The following is a description of a gene set: from publication Chen Y, Wang X (PMID 31504780) Human Gene Set: MIR4311 studied in species Homo sapiens Genes predicted to be targets of miRBase v22 microRNA hsa-miR-4311 in miRDB v6.0 with MirTarget v4 prediction scores > 80 (high confidence targets)., and this is the list of marker genes: AMOT, AFF4, ACVR1C, ARID4B, KIF5B, C2CD2L, DNAJC21, PDLIM5, KAT6A, SNURF, OXR1, AAK1, HSFY2, RASGRF2, CIP2A, SLC24A4, CMAS, LAMP2, CDIP1, TOM1L1, RRP36, UBQLN2, EN2, PLAG1, PTPRR, TATDN3, CATSPERB, HIRIP3, AFP, DIP2C, NDUFB5, AFF2, ZKSCAN1, COLGALT2, TFAP4, NAB2, LCTL, CETN2, SSBP3, KIAA1549, GNRHR, GTF2A1, BAZ2B, MLF1, UBXN4, PAG1, SOX5, LSM12, CLCC1, LANCL1, PALS2, DAW1, MSI2, ERLIN1, LPGAT1, THSD4, STK40, NEXN, SLC4A8, MYLK4, SETD7, TRMT13, SSBP2, PHKG1, RBMS3, RORA, SNX27, NFAT5, IRAK1BP1, ZBTB20, PFDN2, DDX5, VCAN, AURKC, RFX7, WRN, SARAF, SIX4, ABHD17B, TMEM178A, BTBD7, PDE10A, CMTM4, HDAC9, MTTP, GABPA, MTERF4, GRM7, SSX2IP, OTUD4, CPNE8, ATF7, FRA10AC1, RDH10, TENM1, HSD3B2, DCX, MRPL19, SRFBP1, CALCR, LINC02693, MBTD1, C11orf87, CALM1, NEGR1, PRKD3, AR, CPNE3, ALPL, P2RY10, SOX9, VNN1, ZDHHC9, ZNF521, A1CF, SLC17A8, SRSF1, AK7, KIF1B, ZHX3, ATP6V0C (ATPase H+ transporting V0 subunit c), ADA2, SMIM17, VSIG10L, TNFRSF11A, IDS, DHTKD1, NPAS3, SAMTOR, CNTN5, CHAC1, COX15, GID8, IP6K1, RNF144A, PTBP3, POU2F1, IGF2BP2, PCED1B, CREBRF, XRN1, LENG9, CDCA4, GTF2H3, TBCA, ZNF620, HOOK3, RAB3B, TMEM35B (transmembrane protein 35B), EEF2K, WDR43, SP6, AAMP, MYF5, TYRP1, NRAS, GCLC, VOPP1, C2orf76, BBOF1, ZBTB18, HHIP, DOCK5, ZNF641, SMCO3, PABIR2, DAPP1, IRF2BP1, ATM, RRM2B, UNC5CL, ATL2, SLC35A5, IMPA1, EBF2, MAGEB2 (MAGE family member B2), DVL3, RALGPS1, SLC1A2, RUBCNL, BVES, H2AJ, LPP, TICAM2, CLEC10A, WTAP, MAPKAP1, ARMC8, GFRA1, RAD18 (NCBI Gene Id 56852), PECAM1, NPAT, CEACAM7, TEAD1, MSL2, HSPE1 (heat shock protein family E (Hsp10) member 1), CDK2AP1, RUNX1T1, CYP8B1, CLIC5 (NCBI Gene Id 53405), INO80D, MXI1, SERPINB1, KRTAP9-4 (keratin associated protein 9-4), YTHDF3, ACO1, TRIO, ESR1, RASAL2, SPIN4, PRR23E, KCNJ2, LZTFL1, MID1, ZNF2, GRM5, NCAM2, GRIK4, IGSF23, ZNF800, KCNK1 (potassium two pore domain channel subfamily K member 1), TRIM50, CADM2, KLRG1, ABLIM3, CCDC141, TOX2, TGFA (transforming growth factor alpha), KPNA3, CBL, MTFR1, TTC17, CNTNAP5, ATF7IP, CD1D, ACTR3 (actin related protein 3), PGAP4, SRGAP2B, ELMOD2, PCSK6, FMNL2, ANXA2R, NMBR, ESRRG, SLMAP, SESN3, ADIPOQ, CALHM4, TP63, SYT16, DNAAF6, B4GALT6 (beta-1,4-galactosyltransferase 6), PPDPFL, DCAF10, TUBB2B, C19orf12, SESTD1, MTBP, CALHM5, XRCC5, TMED7-TICAM2, JAK1, OXGR1, ENPP3, CSRNP3, RAD51B, GPR180, SLC39A10, BPY2B, GIPC2, RNF128, HEATR5B, FCMR, IKZF1, SAMD8, DNAJC6, NUCKS1 (NCBI Gene Id 64710), TWF1 (NCBI Gene Id 82712), DUSP6, L3MBTL3, ETV1, ST8SIA4, MEF2C, PM20D2, MC5R, ATP6V1B2 (NCBI Gene Id 526), NEK9, BDP1, GATAD1, ARHGEF9, SVIL, SPARC (secreted protein acidic and cysteine rich), KCNC2, COL1A2, GMPR, SRCIN1, DGKI, EGFL8, KCNMA1, SH3GLB1, RAD54L2, DGKH, RREB1, RCAN2, RAB14, ARID1B, BPY2, CLCN5, TIPIN, CWC25 (CWC25 spliceosome associated protein homolog), SEH1L, ENTPD5, SNRPN, C1GALT1, DERL1, FYB1, ATP2C1, EXOC2, PCDH15, EPHA3, EBF1 (NCBI Gene Id 1879), PRAMEF2, SENP1, SLC36A4, GPR88, TRDN, CTCFL, RNF139, ALCAM, SNIP1, WNT16, ZHX2, UBR7, EDIL3 (NCBI Gene Id 10085), PRKCE, CACNA1E, ANGEL2, ZNF611, C21orf91, SEMA5A, SLIT1, SEMA6A, ATP2B1, PTGER3, WDR12, LRRC41, ZC3H12B, RTKN2, FOXG1, LAPTM4A, BAMBI, NUDT3, GIGYF2, CAMK2N1, TMEM260 (NCBI Gene Id 54916), ASH1L, HSFY1, BPY2C, HSPA2, CPEB4, SCAF11, KLF4, ZNF275, TEX55 (testis expressed 55), RIMS2, NCAPG, F9, ATP11B, LRIF1, CFAP52, CASK (calcium/calmodulin dependent serine protein kinase), RAB3GAP1